The following is a description of a gene set: species: Mus musculus This event has been computationally inferred from an event that has been demonstrated in another species.<p>The inference is based on the homology mapping from PANTHER. Briefly, reactions for which all involved PhysicalEntities (in input, output and catalyst) have a mapped orthologue/paralogue (for complexes at least 75% of components must have a mapping) are inferred to the other species. part of: Assembly of the pre-replicative complex Reactome Pathway: CDC6 association with the ORC:origin complex electronically inferred by orthology from the curated human pathway, and this is the list of marker genes: Orc1, Orc5, Mcm8, Cdc6 (NCBI Gene Id 23834), Orc3, Orc4